Given this list of marker genes NPAS3, TMED1, NR2F6, POMT2, ZNF20, RFX2, TGFB3, LAMB2, RFXANK, SLC12A4, ACSBG1 (NCBI Gene Id 23205), EYA2, TBX2, MEIS1, ADAM19, PTPRA, MYO5C, CLIP2, DOCK6, KLHDC8A, PLA2G5, ITGA7, CC2D1A, B3GALT1, ERCC2, TGIF2, SHFL, PEPD, PCSK5, SHOX2, NDP, DAG1, ZNF304, PRKD2, KLHL25, CDH4, BMAL1, GRIK5, NPEPL1, ZNF606, CREB5, DENND2A (NCBI Gene Id 27147), BLM, ILK, SLC2A10 (solute carrier family 2 member 10), ZNF227, PLIN3, OSBPL3, QTRT1, PIPOX, ZNF235, GALNT4, TRIB2, GSTK1, GJA1, SPRY2, LRP10, ARAP3, ZNF446, DLC1, RASGRP1, ITGB8, SEPTIN11, CALM1, FGFR3, SOX9, ANXA5, CDK6, GARRE1, MLC1, SMO, SARS2, APBA3, ZNF134, TRIP6, RBCK1, VPS16, RGS6, SIPA1L1, TLE2, ZNF112, PRPF31, KCNF1, LFNG, ZNF8, MCC, HSPBP1, AKT2, R3HDM4, FZD7, DMWD, LRP5, SSH3, RBM42, ADGRE5, GAS1, MAB21L1, SLC6A9, NOS2, ABCD2, ACSS3, FZD3, LMO2, KEAP1 (NCBI Gene Id 9817), NES, HS3ST3B1, HMG20B, MEOX2 (NCBI Gene Id 4223), ADGRG1, ZNF264, EXTL3, SNTA1, MEGF8, JUND, VAV3, PMP22, ZFHX4, ZNF211, LRFN3, FBXO17, SLC6A11, SEMA6A, SLC4A4, ZNF419, CDH6, IRS2, ELOVL2, RGS12, CARMIL1, GNG7, POFUT1, RIN1, ARAP2, BTBD2 (NCBI Gene Id 55643), CD151 (CD151 molecule (Raph blood group)), WSCD1 (NCBI Gene Id 23302), GNAS, TMEM161A, SCAMP4 (NCBI Gene Id 113178), GLG1, LHFPL6, JAG1, ZNF45, GRIK1, POLR1G, SOCS2, ACSL3, PDGFA, SEMA6D, EGFR, EPHB4, IRF3, CDH2, ZNF671, KLHL4, TEAD3, GLI2, TMEM147, PTPN14, CAMK2B, NR2E1, here is a description of the gene set: from publication Verhaak RG, Hoadley KA, Purdom E, Wang V, Qi Y, Wilkerson MD, Miller CR, Ding L, Golub T, Mesirov JP, Alexe G, Lawrence M, O'Kelly M, Tamayo P, Weir BA, Gabriel S, Winckler W, Gupta S, Jakkula L, Feiler HS, Hodgson JG, James CD, Sarkaria JN, Brennan C, Kahn A, Spellman PT, Wilson RK, Speed TP, Gray JW, Meyerson M, Getz G, Perou CM, Hayes DN, Cancer Genome Atlas Research Network (PMID 20129251) Human Gene Set: VERHAAK_GLIOBLASTOMA_CLASSICAL studied in species Homo sapiens Genes correlated with classical type of glioblastoma multiforme tumors. The Cancer Genome Atlas Network recently cataloged recurrent genomic abnormalities in glioblastoma multiforme (GBM). We describe a robust gene expression-based molecular classification of GBM into Proneural, Neural, Classical, and Mesenchymal subtypes and integrate multidimensional genomic data to establish patterns of somatic mutations and DNA copy number. Aberrations and gene expression of EGFR, NF1, and PDGFRA/IDH1 each define the Classical, Mesenchymal, and Proneural subtypes, respectively. Gene signatures of normal brain cell types show a strong relationship between subtypes and different neural lineages. Additionally, response to aggressive therapy differs by subtype, with the greatest benefit in the Classical subtype and no benefit in the Proneural subtype. We provide a framework that unifies transcriptomic and genomic dimensions for GBM molecular stratification with important implications for future studies.